Given this list of marker genes Pten, Trp53, Nf2 (NCBI Gene Id 18016), Stk11, Tsc2, here is a description of the gene set: studied in species Mus musculus Mouse genes annotated to increased hamartoma incidence (MP:0010306) retrieved from the Mouse Genome Informatics database via MouseMine from publication Motenko H, Neuhauser SB, O'Keefe M, Richardson JE (PMID 26092688) Mouse Gene Set: MP_INCREASED_HAMARTOMA_INCIDENCE